The following is a description of a gene set: Genes positively differentially expressed in cell type: Treg upon treatment with cytokine: IFN-κ in mouse lymph nodes in vivo. Cytokines mediate cell-cell communication in the immune system and represent important therapeutic targets. A myriad of studies have highlighted their central role in immune function, yet we lack a global view of the cellular responses of each immune cell type to each cytokine. To address this gap, the authors created the Immune Dictionary, a compendium of single-cell transcriptomic profiles of more than 17 immune cell types in response to each of 86 cytokines (>1,400 cytokine-cell type combinations) in mouse lymph nodes in vivo. A cytokine-centric view of the dictionary revealed that most cytokines induce highly cell-type-specific responses. For example, the inflammatory cytokine interleukin-1β induces distinct gene programmes in almost every cell type. A cell-type-centric view of the dictionary identified more than 66 cytokine-driven cellular polarization states across immune cell types, including previously uncharacterized states such as an interleukin-18-induced polyfunctional natural killer cell state. species: Mus musculus from publication Cui A, Huang T, Li S, Ma A, Pérez JL, Sander C, Keskin DB, Wu CJ, Fraenkel E, Hacohen N (PMID 38057668) Mouse Gene Set: CUI_TREG_IFNK_RESPONSE_UP, and this is the list of marker genes: Irf7, Usp18, Rtp4, Ifi208, Sp110 (NCBI Gene Id 78814), Ifih1, Psmb9, Sp100, Epsti1, Psmb8, Ifi213, Samd9l, Zbp1, Dhx58, Trim12c, Asb13 (ankyrin repeat and SOCS box-containing 13), Ifi203, Rsad2, Trim30d, Ccnd2 (NCBI Gene Id 97325), Oasl2, Ifi209, Dtx3l, Parp9, Trim25, Trim56, Ifi47, Stat1, Rnf213, Herc6, Ifi206, Slfn8, Slfn2, Phf11c, Oas3 (2'-5' oligoadenylate synthetase 3), Tapbp, Irgm1 (NCBI Gene Id 15944), Lgals3bp, 9930111J21Rik2, Parp14, Pml, Bst2, Tap2, Eif2ak2, Ms4a6b, Slfn1, Lgals9, Tspo, Psmb10 (proteasome (prosome, macropain) subunit, beta type 10), Rigi, Igtp, Isg15, Samhd1, Uba7, Isg20, Ifit3, Helz2, Gbp7, Stat2, Ifi35, Xaf1, Ms4a4b, Ifi214 (NCBI Gene Id 545384), Mndal, Mitd1 (NCBI Gene Id 69028), Trim30a, Ddx24, Shisa5, Ifit1, Tcstv4, Usp25, Ly6a, Ddx60, Ly6e, Ifit1bl1, Phf11b, Ifit3b, Ifi27l2a, Slfn5, Trim12a, H2-T23, H2-T22, Iigp1